The following is a description of a gene set: Mouse Gene Set: REACTOME_IMMUNE_SYSTEM Immune System species: Mus musculus, and this is the list of marker genes: Anxa2, N4bp1, Rap1b, Mgam, Atp6v0a2, Calm2, Try5, Arih2, Il22ra1, Nckap1l, Asb17, Stim1, Dync1li2, Defa36, Kif1a (NCBI Gene Id 403189), Acp3, Tap1, Rab6a, Kif28, Uba6, Ftl2-ps, Znrf2, Ctsl, Cd93, Hexb, Tax1bp1, Ckap4, Tnfrsf8, Tifa, Mapt, Abl1, Capza2 (NCBI Gene Id 76913), Cd80, Arsb, Il10ra, Ltn1, Acaa1b, Il6ra, Nectin2, Dnajc3, Igf2r, Atp8a1, Prkacb, Dnase1l1 (deoxyribonuclease 1-like 1), Stk10, Rap1gap2, Trac, Psmd2, Btbd1, Raet1e, Grb10, Nkiras1, Atp6v1g1, Bcap31, Mme, Plcg2, Il33, Tnfrsf13b, Ighv8-8, Frk (fyn-related kinase), Ptafr, Map3k3, Trat1, Atp6v0e2, Fbxw11, Smarca4, Dctn3, Hectd1, Lyn, Klhl42, Ighv3-8, Ctf1, Sarm1, Psmd14, Ifna2, Vcam1, Gyg1, Rnf138, Pnp2, Syngr1, Ighv13-2, Tubb1, Socs3, Stxbp2 (NCBI Gene Id 97457), Hk3, Cd59b, Cd22, Pdia3, Dsp, Dus2, Eif4a3, Cd46, Icos, Pirb, Siglec1, Cd53, Cd274, Gpr84, Pdzd11, Psma5, Kif26a, Anpep, Fbxo32, Cul1, Psmc5 (NCBI Gene Id 19184), Vat1, Ube2f, Ifnab (NCBI Gene Id 15974), Psme1, Ube2k, Ppp2r5c, Mospd2, Prcp, Slc2a3, Ifna7, Ubr2, Lrr1, Socs2, Ypel5, Psma2, Apaf1, Galns, Bcl10, Siglech, Uba7, Retn (NCBI Gene Id 65097), Socs5, Ube2g1, Il13, B4galt1, Prss1l, Dynlt1a, Bcl2l1, Shc1, Igkv17-121, Fbxo11, Treml2, Ikbke, Prss3, Mapk11, Brwd1, Dync1h1, Cd300lg, H2-M1, Hbb-bt, Map3k8, Defb1, Pstpip1, Ube2l6, Lamp2, Defa39, Tnfsf8, Nos2, Cr2, Psg29, Wasf3, Cd27, Fgg, Lrrc41, Ncf4, Dpp7, Fbxo30, Atad3a, Atp6v1c1, Ms4a2, Ighg3, Cyfip2, Tab1, Art1, Rac2, Irak2, Ifi44, Irak4, Ear14, Txlna, Abca13, Atp6v0e, Fancf, Slc11a1, Tmbim1, Actb, Tnfsf12, Rnf34, Il22ra2, Ppp2r5e, Tnf, Klc2, Ube2v2, H2-M9, Tnfsf13, Ptk2b, Pafah1b2, Ube2j2, Il5ra, Hsp90ab1, Prr5, Cd28, Ifna15, Cul2, Lcp2, Faap24, Ccr6, Sphk1, Kif18a, Hbb-bs, Pigr, Nhlrc3, Txndc5, Tubb4a, Psmb3, Col1a2, Eda, Vrk3, Dsg1a, Xrcc6, Mrc2, Eif4g1, H2-Q4, Igkv8-21 (immunoglobulin kappa variable 8-21), Pdpk1, Bst2, Ube2e2, Cbll1, Ptpn6, Cpn2 (NCBI Gene Id 71756), Sec24a, Stat6, Idh1, Lamp1, Pld3, Capzb, Neu1, Rnf114, Il18 (interleukin 18), Nfkb1, Tnfsf4, Psmd6, Cfb (NCBI Gene Id 14962), Eif4g2, Klhl5, Zap70, Cd96 (CD96 antigen), Becn1, Ear2, Klhl3, Fancl, Fbxo17, Bst1, Sqstm1, Trip12, Hmgb1, Dhx36, Rnf220, Il27ra, Defa38, Ighv12-3, Cd79a, Adar, Wipf1, Ighe, Klrd1, Fos, Sec24c, Fpr2, Psmb6, Ap1m1, Lonrf1, Vav2, Eif4g3, Mlst8, Impdh1, Skp1, Tuba8 (tubulin, alpha 8), Kir3dl1, Irak1, Dnm2, D1Pas1, Trem2, Il5, Psmb7, Pias1, Mavs (NCBI Gene Id 228607), BC051665, Ighv5-12, Tab3, Fpr1 (NCBI Gene Id 14293), Ifitm1, Ighv8-6, Ifit1bl2, Cap1, Inpp5d, Il6, Reg3g, Siglec15, Cd8b1, Igkv2-137, Alad, Edar, Cntf (ciliary neurotrophic factor), Rnf144b, Ddost, Panx1, Colec11, Nfam1, Ube2d1, Asb5, Tspan14, Kif20b, Tollip (toll interacting protein), Rela, Oasl1, Dync1li1, Ms4a3, Btk, Tnfrsf17, Mapkap1, Kif20a, Fcgr1, Camk2d, Lamtor1, Ptprn2, Tuba4a, Il34, Ddx3x (DEAD box helicase 3, X-linked), Uba1, Psmb8, Cul7, Tbc1d10c, C6, Ighv5-12-4, Pglyrp2, Kif4 (NCBI Gene Id 194650), Tnfrsf4, Ep300, Qpct, Anapc4, H2-T10, Svip, Naprt, Actr2, Ighv5-6, C8b (NCBI Gene Id 73971), Plcg1, Rnf123, Tmem30a, Gaa, Rnf19b, Ube2m, Itk, Rab14, Hecw2, Tnfrsf12a, Rab4b, Mapk10 (mitogen-activated protein kinase 10), Rbbp6, Fabp5, Ube2v1, Slc2a5, Tyrobp (TYRO protein tyrosine kinase binding protein), Dynlt1b, Hras, Rapgef4, Hspa1b, Kif11, Ctsa, Eif2ak2, Fbxl7, Ifitm6, Cd3g, Fyb1, Snap29, Ahsg (NCBI Gene Id 11625), Scamp1, Chrnb4, Pgam1, Stk11ip, Nkiras2, Kif12, Mapk14, Igkv16-104, Gusb (glucuronidase, beta), Pdcd1, Sirpa (signal-regulatory protein alpha), Mefv, Cntfr, H3c7, Prdx6, Ifng, Mapk9, Them4, Fbxw5, Prkce, Psme2b, Arpc3, H3c2, Clec4n, Sptbn2, Il31ra, Il20rb, Pde12, Actg1, B2m, Ighv5-15, Serpinb3a, Madcam1, Nfasc, Crkl, Sos1 (SOS Ras/Rac guanine nucleotide exchange factor 1), Eif4a2, Gan, Pa2g4, Sh3kbp1, Fbxl5, Ctsh, Gsdmd, Pdxk, Gstp1, Dctn6, Ybx1, Trbv15, Tnfsf11, Traip, Atg7, Cd40lg, Hpse, Anapc1, Vav3, Ap1b1, Mapk3, Rnf19a, Kbtbd7, Ctse, Nme2, Arl8a (ADP-ribosylation factor-like 8A), Rnf213, Akt1, Fbxo41, Defa23, H2-Q7, Lta, Prdx4, Atp6v1e1, Atp6v1g3, Capn1, Fkbp1a, Defa25, Ppbp, Ube3b, Serpinb1a, Cbl, C1s2, Tnfrsf1b, Ifnlr1, Herc6, Tnfaip6, Ighv3-5, Csk, Cdc26, Rictor, Cnpy3, Psma3, Ptprj, Ufl1, Socs1 (suppressor of cytokine signaling 1, NCBI Gene Id 12703), Capza3, Kctd6, Rab9b, Pfkl, Crtam, Pkp1, Dtx4, Ube2h, Tubb3, Vamp8, Cd44, Pglyrp3 (peptidoglycan recognition protein 3), Tnfrsf14, Uba52, Alpk1, Anapc7, Arpc4, Fkbp5, Sell, Svs3b, Creg1, Tlr2 (toll-like receptor 2), Siah1a, Masp2, Ctso, Nit2, Syk, Ceacam1, Abce1, Ggh, Defa30, Ighv3-1, Txnip, Xdh, Cdc20, Tlr9, Hspa1a, Smurf2, Ticam2, Calm1, Klhl22, Cand1, Tnfsf15 (NCBI Gene Id 326623), Kpna1, Ifngr2, Cd79b, Ifnl2, Irs2, Serpina1b, Kif27, Serpinb10, H2-Ob, Ube4a, Sdcbp (NCBI Gene Id 53378), Uba5, Klrk1, Commd9, Cd34, Kcnab2, Defb30, Rac1, Cblb, Ctsb, Fcgr3, Ighv8-9, Trim21, Myh9, Tuba1a, Asb4, Il20ra, Wipf3, Kir3dl2, Ptprc, Txk, Arih1, Hspa8, Rbsn, Sh3rf1, Il9, Klc3, Tmem63a, Pnp, Pak3, Anapc10, Nfkbia, Ampd3, Pik3r1, Pkm, Calm4 (NCBI Gene Id 93787), Kif1c, C5ar1, Myd88, Il15ra, Icam1, Ighv8-11, Fbxo4, Apeh, Kifap3, Sec23a, H2-Q10, Fbxw7, Mmp9, Ifitm2, Ticam1, Trappc1, Reg3b, Cat, Abl2, Cct2, Pilra, Cd63, Trem1, Ppp2r1b, Elmo2, Fuca2, Trim37, Ighv5-17, Potefam3d, Cfhr1, Ighv5-9, Cpne1, Defb43, Ppl, Rock1, H3c3, Sting1, Ifna9 (NCBI Gene Id 15972), Il24, Treml4, Sdc1, Camp, Lrrc14, Src, Adam10, Mgrn1, Itpr3, Rap2c (NCBI Gene Id 72065), Igkv11-125, Cyld, Cdc16, F2 (coagulation factor II), Fbxl3, Kcmf1, Dnm1, Folr2, Kif2a, Irf9, Lck, Ear1, Bpi, Il23a, Rnaset2b, Kif3c, Det1, Rap2b, Cda, Spsb4, Cxadr, Tslp, S100a11, Bri3, Copb1, Klhl2, Herc3, Rab3d, Olr1, Atp6v0c, Il4ra, Prss2, Itgax, Prkcd, Dtx3l, Ap2s1, Serping1, Npdc1, Defa35, Padi2, Lta4h, Blmh, Defa27, Card9, Rnase6, Camk2a, Psmd8, Defb25, Peli3, Vapa, Psmb4, Fbxl13, Il12a, Brk1, Apob, Ecsit, Bin2, Psmd12, Bpifb2, Commd3, Rnf115, H3c6, Ctsz, Ctsd, Stub1, Dynll2, Tnfaip3, Igkv1-135, Kras, C3ar1, Defb47, Ube2o, Fbxo10, Icam4, Tap2, C1qc, Traf6, Slpi, Kpnb1, Racgap1, Fyn, Faf2, Chga, Tlr4, Psmc3, Atp6v0d2, Rnf25, Qsox1, Relb, Kif19a, Atox1, Il2, Hace1, Rasgrp3, Plekho2, Nod2, Kctd7, H2-M5, Casp8, Rasgrp1, Hgsnat, Edaradd, Tnfrsf9, Mapk1, Fbxl21, C9, Klhl25, Cd4, Rps6ka3, Mx2, Cyfip1, Grap2, Plaur, Pik3ca, Cxcr1, Ppp3ca, Pgm1, Tomm70a, Itch, Ighv7-3, Cep290, Ano6, Pira2, Fbxw4, Il20, Aamp, C1qa, Igkv18-36, Dctn4, Klhl11, Psap, Ubc, Usp18, Cdk1, Ighv7-4, Ighv8-12, Csf1r, Thop1, Tlr8, Kif16b, Cd300c2, Cd101, Hectd3, Atp6v0d1, Vcp, Rnf41 (ring finger protein 41), Atp8b4, Defa24, Il12b, Ltb, Trim25, Serpinb3b, Map2k4, Atp6v1h, Sh2b1 (NCBI Gene Id 77601), Nlrx1, Cdk13, Kbtbd13 (NCBI Gene Id 74492), Fancc, Huwe1, Gzmm, Erap1, Ifi204, Clu, Defa40, Ctss, Il13ra1, Il16, Cnn2, Cd36, H2-T23, Mapkapk3, Anapc5, Fanca, Pik3cd, Prl, Clec4g, Spsb2, Nedd4, H2-M10.6, H3c14, Herc2, Il13ra2 (interleukin 13 receptor, alpha 2), Traf2, Npm1, Ripk1, Psmb5, Hvcn1, Klhl9, Psmc2, Itln1, Pecam1, Rap1a, Kif3a, Canx, Igkv1-99, Spsb1, Cd74, Cdkn1b, Pik3cb, Trim11, Tlr1, Sftpd, Aga, Siglecf, Defa37, Pgm2, Snap25, Pdcd1lg2, Dzip3, Gdi2, Ppp2r1a, Defa3 (NCBI Gene Id 13237), Inppl1, Fbxo22, Itga4, Pianp, Plpp5, Rnf4, Siglecg, Il2rg, Hebp2, 1600012H06Rik, Ifna12 (interferon alpha 12), Peli1 (pellino 1), Fadd, Tarbp2, Wasf2, Cdc27, Psen1 (presenilin 1), Iqgap1, Kif23, Igkv1-88, Pik3r5, Ppia, Hsp90aa1, Psg22, Col1a1, Itgav, Irf3, Ube2l3, Csf1 (NCBI Gene Id 97111), Trpm2, Wwp1, Calr (NCBI Gene Id 12317), Tlr6, Clec4e, Rigi, Dnm3, Mapk7, Mre11a, Yes1, Trbv16, Siglece, Atp11b, Sorbs2, Fbxo9, Ttr, Sec13, Try10 (NCBI Gene Id 436522), Ifnl3, Trim36, Mex3c, Ighv5-9-1, Asb18, Fbxl15, Eef2, Psma7, Ppp2cb, Klhl21, Xiap, Nck1, Akt3, Ly86, Ap1s1 (adaptor protein complex AP-1, sigma 1), Asb9, Kif22, Ppm1b, Il7, Ubox5, Stom, Gh, Ube2w, Il1f10, Atp11a, Fbxw9, 2310033P09Rik, Atf2, Tapbp, Hspa5, Fcer1g, Impdh2, Defb14, Ighv7-2, Faap100, Kif26b, Asb7, Ghdc, Cd47, Cd81, Elane, Glipr1, Anapc2, Krt1, Tnfsf18, Igkv1-110, Tank, Ube2e1, Btnl2, Defa28, Jaml, Orm2, Eif4e3, Ist1, Rhoa, Col17a1, Fbxo21, Degs1, Tuba3a, Fuca1, Dnajc5, H2-DMb1 (histocompatibility 2, class II, locus Mb1, NCBI Gene Id 14999), Jup, Kifc5b, Slco4c1, Chi3l1, Il12rb2, H3c13, Tlr7, Il2ra, Btn2a2, Cotl1, AY761185, Tyk2, Dusp7, Asb8, Camk2g, Hectd2, Surf4, Ube3a (ubiquitin protein ligase E3A), Kif18b (kinesin family member 18B), P2rx7, Defa41, Nlrp4c, Birc3, S100a1, Tubb2b, Defb4, Mapk12, Dctn2, Grn, S100a9, Itpr1, Btn1a1, Il1r1, Magt1, Casp4, Cant1, Cd300a, Fbxl4, Ebi3, Cenpe, Hck, Lcn2, Myo10, Nfkbib, Ear10, Ghr, Hc, Orm3, Atp6v1b1, Ormdl3, Cd3e, Epx, Clec5a, Gpi1, Ube2b, Il18bp, Raf1, Ctnnb1, Pag1, Lat2, Dynlt1f, Ltbr, Il36b, Eef1a1, Fbxl14, Arel1, Ilf3, Itgam, Ube3c, Ifngr1, Bpifb6, Ppp2r5b, Rbx1, Ighv6-6, Mapk8, Clcf1, Igkv2-112, Rab5c, Limk1 (NCBI Gene Id 547389), Il23r, Sugt1, Ifi205, Grb2, Cd247, Mapkapk2, Psmd11, Rnase2a, Fbxo15, Arpc2, Fzr1, Leap2, Sla2, Elob, Mvp, Herc1, Dusp4, Psma4, Fbxl12, Manba, Rel, Il6st, Cracr2a, Ube2q2, Trim39, Blnk, Nckipsd, H3c15, H2-Q2, Trim41, Igkv1-133, Trim50, Lgmn, Hp, Stat3, Nlrc5, Il21r, Nbeal2, Il36a, Znrf1, Faap20, Fgl2, Fbxo2, S100a8, Il21, Ighv5-4, Il1rap, Il22, Icosl, Trav19, Npepps, Stat2, Ubac1, C8g, Prss3l, Defa22, Bpifa1, Nf2, Arhgap9, Ighg1, Chit1, Enpp4, Cd180, Defb42, Psma1, Kifc1, Treml1, Igkv1-132, Nos1, Ifna13, Actr10, Rlim, Il1r2, Ctla4, Pglyrp4, Optn, Serpinb3c, Ighv16-1 (NCBI Gene Id 629812), Klhl13, C1ra, Rab7, Tubb5, Il1rapl1, Ighv3-4, Lifr, Tbk1, Cab39, Fbxo31, Plau, Kif21a, Sumo1, Abi2, Pja1, Ywhaz, Asb10, Asb13, Ifna5, H2-M11, Ighd, Nlrp3, Eppin, Rnf130, Gca, Jak2, Jun, Casp2, Fbxo44, Traf3, Vamp3, Creb1, Vtn, Mif, Pvr, Cd8a, Gm2a, Mcemp1, Defa42, Slamf6, Dgat1, Defa17, Vhl, Iglc2 (NCBI Gene Id 16138), Klc4, Klhl41, Hrnr, Mmp25, Itpr2, Cul3, Prkn, Pik3r3, H2-Oa, Flg2, Fbxw10, Mapk13, Ifnar1, Myo1c, Fancb, Ndufc2, Ap1m2, Aprt, Fcer1a, Dync1i2, Stat5b, Kif5a, Kif9, Sec24b, Fbxw17, Lat, Tnfsf9, Dcaf1, Actr1b, Trav16, Mgst1, Unc93b1, Mtor, Rps6ka1, Irf5, Man2b1, Il19, Il15, Rnf126, Map3k7, Rhog, Anapc13, H2-T22, Arpc1b, Clec4d, Sec31a, Timp2, Lpcat1, Pik3c3, C5ar2, Psmd3, Kif1b, Igkv15-103, Ncf2 (NCBI Gene Id 17970), Flnb, Ap1g1, Cpn1, Ap2m1, Ctsk, Actr3 (NCBI Gene Id 74117), Defa5, Tmem179b, Myo5a, H3c8, Aldoc, Dapp1, Arpc1a, Igkv1-35, Pak1, Tuba1c, Ube2n, Il11ra1, Ube2q1, Myo9b, Ube2c (NCBI Gene Id 68612), Mkrn1, H2-M10.4, Nos3, Nfatc1 (nuclear factor of activated T cells, cytoplasmic, calcineurin dependent 1), Csf2rb, Igkv2-109, H3c1, Map2k6, Ctsg, Ptprz1, Arsa, Tmc6, Fga, Atp6v1c2, Ube2r2, Pglyrp1, Bpifa2, Slc27a2, Il10, Gsn, Bpifb1, Hsp90b1, Ctsc (cathepsin C), Rnf217, Cenpx, Adrm1, Itgb2, Rab31, Tnfsf14, Srp14, Ptpn22, Ptges2, Slc44a2, H2-Aa, Cd160, Ighv3-6, Ripk3, Rab10, Rhof, Dhx9, Sar1b, Prkcq, Defa21, Ikbkg, Gns, Rasgrp2 (NCBI Gene Id 386467), Ptpn11, Fcgr2b, Stat5a, Cfd, P4hb, Il36rn (interleukin 36 receptor antagonist), Irak3 (NCBI Gene Id 73914), Prlr, Ager, Stx1a, Reg3a, Cd55, Vamp2, Rnaset2a, Nfkb2, Crispld2, Calm3, Baiap2, Cd14, Ppp2ca, Ap2a1, Ly96, Actr1a, Tubb2a (tubulin, beta 2A class IIA), Igkv1-122, Trp53, Tnfrsf18, Ube2z, Arpc5, Usp14, Defa31, Ifna11, Frmpd3, Traf7 (NCBI Gene Id 224619), Asb6, Asb16, Acly, Crk, Csf2 (NCBI Gene Id 12981), Lif (leukemia inhibitory factor), Ifna4, Arg1, Ighv5-2, Stx4a, Ptpn4, Ikbkb, Ube3d, Armc8, Lrrc7, Cd200, Ddx41, Eif4e, Prtn3, Klc1, Ifitm3, Asb12, H2-Eb1, H2-M3, Kif5b, Kif15, Psmc1, Osm, Tirap, Klhl20, Ptk2, Cfp, Ppp3cb, Atp6v0a4, H3c11, Atp6v1g2, Herc4, Masp1, Hspa1l, Stx3, Cd200r2, Kbtbd8, Eea1, Cxcr2, Cd70, H2-M10.2, Lamtor3, Cd3d, Klrc3, Wsb1, Rab18, Prg3, Tuba1b, Kif2b, Nfatc3, Pld4, Cfi, Ptpn1, Fgr, H2-Q6, Tarm1, Gsdme, Fbxw2, Cdc23, Ncf1, Dnajc13 (DnaJ heat shock protein family (Hsp40) member C13), Lpo, Defa29, Pik3cg, Ifnb1, Lmo7, Ubr1, Kif2c, Psmb1 (proteasome (prosome, macropain) subunit, beta type 1), Prkg1, Rab5b, Fbxo40, Tuba3b, H2-K1, Fbxl16, Serpinb12, Kif3b, C2, App, Irf7, Dctn1, Defb18, Serpina3f, Mndal, Klrc2, Tcirg1, Eif4a1, Sh2b3, Defa26, Atp6v1f, Map3k14, Mbl2 (NCBI Gene Id 17195), Rnase2b, Trim69, Fbxl8, Casp3, Uba52rt, Psme2, Aldoa, Cd33, Nod1, Ear6, Flt3l, Pygb (brain glycogen phosphorylase), Cmtm6, Ppp3r1, Mylip, Atp7a, Mmp8 (matrix metallopeptidase 8), Erp44, H2-DMb2, Tnfrsf11b, Gmfg, Sec24d (NCBI Gene Id 69608), Mlec (NCBI Gene Id 76765), Lamtor2, Peli2, Ap1s2, Psmb10, Vav1, Defa34, Ighv6-5, Cystm1, Cyb5r3, Atp6v1b2, Nlrp1a, Psmd1, Oscar, Tnfrsf13c, Iqgap2, Cd1d1, Cdc42 (NCBI Gene Id 12540), Pik3r6 (NCBI Gene Id 432574), C7, Psmc4, Tab2, Csf3, Itgb7, Defb19, H2-DMa, Defa32, Fance, Defa43, Cd177, Stbd1, Lrsam1, Cltc, Rps27a, Il9r, Clec12a, Adam8 (NCBI Gene Id 11501), Snca, Cpne3, Psma6, Il31, Ighv3-3, Psmd13, Ptx3, Trim32, Dock2, Fbxw8, Kifc2, Fbxl19, H2-Eb2, Mpo, Dynlt1c, Plpp4, Cyba, Card11, Csf2rb2, Foxo3 (forkhead box O3), Skp2, Rbck1, Fancm (NCBI Gene Id 52599), Fth1, Rab27a, Itgal, H2-M10.3, Prg2, Rnf7, H3c10, Adgrg3, Map2k7, Socs6, Cd68, Rab44, Prss1, Siah2, Agpat2, Pin1, Ncstn, Rps6ka5, Ltf, Hspa2, Il18rap, Btbd6, Igkv1-131, Atf1, Ifi44l, Fcna, Ighg2c, Try4, Defa2, Il10rb, Pgrmc1, Ighv5-16, Dera, Rap1gap, Psmd7, Unc13d, Fbxl18, Rnf182, Sec22b, Fbxo6 (F-box protein 6), Rnasel, Trim71, Rilp, Lnx1, Il1b, Cfh, Ptprb, Dok3, Vnn1, Pira13, Myh2, Il36g, Snap23 (synaptosomal-associated protein 23), Ceacam2, Pja2, Osmr, Bcl2, Reg3d, H3c4, Rps6ka2, Aoc1, Csnk2b, Cd300e, Kif13b, Defb36, Anapc11 (anaphase promoting complex subunit 11), Pycard, Ap2b1, Camk2b, Il7r, H2-M2 (histocompatibility 2, M region locus 2), Cxcl1, Defb28, Cpb2, Cd19, C1qb, Ubr4, Slamf7, Plac8, Mib2, Sos2 (SOS Ras/Rho guanine nucleotide exchange factor 2), Birc2, Arf1, Trim9, Nckap1, Asb11, Cenps, Aim2, Elmo1, Gla, Txn1, Golga7, Npc2, Fancg, Rnf6, Rab37 (RAB37, member RAS oncogene family), Atp6v1d, Vcl, Dctn5, Orm1, Pdap1, Ighv8-2, Il27, Dynll1, Fcgr4, Serpinb3d, Pik3r4, Il1rl2, Ccnf, Psmc6, Vps35l, Dync1i1, Adgre5, Pla2g2a, Pla2g6, Prkcb, Rab24, Lair1, Atp6v0a1, Aldh3b1, Tnfrsf11a, Gstp2, Lilra6, Ripk2, Pira12, Pik3ap1, Prkra, Ifna16, Iglc1, Glb1, Dsn1, Col2a1, Olfm4, Defa20, Clta, Ifna6, Cpped1, Pten, S100b, Ube2g2, Tnip2 (NCBI Gene Id 69105), Casp9, Ube2a, Atp6ap2, Ighv6-3, Tasl, Cd40, Ilf2, Ighv8-4, Cd86 (CD86 antigen), Uba3, H2-M10.5, Col3a1, Bpifb4, Sh3gl2, Ppp2r5a, Ubb, Eda2r, Ube2s, Il3, Ifnar2, Asb14, Il1rn, Il11, Osbpl1a, Igkv20-101-2, H2-Q1, Lag3, Pld2, Fbxo7, Arhgap45, Ube2d3, Pik3r2, Ywhab, Atp6v1a, Asah1, Lyz2, P2rx1, Kif6, Dock1, Ap2a2, Tubb4b, Ostf1, Sipa1, C4b, Rapgef3, Tom1, Fbxl20, Alox5, Xrcc5, Ap1s3, Slc15a4, Atp6v0b, Ube2j1, Il12rb1, Psg18, Serpinb6a, Gm5150, Lilra5, Sla, Unkl, Smurf1, Nedd4l, Ube2e3, Tnfsf13b, A1bg, Rnf111, Hcst, Ifna14, Cybb, Fbxo27, Isg15, Ppp2r5d, Il4, H2-Ab1, Sptan1, Wasf1, H2-M10.1, Casp1, Akt2, Eif4e2, Fcnb, Cst3, Btnl9, Ctsf, Crlf1, Igkv1-117, Cd300lb, Fgb, Tubb6, Ighv8-5, Psmb2, Pak2 (p21 (RAC1) activated kinase 2), Il1rl1, Colec10, Kif21b, Ighv8-13, Defb48, Prkaca, Ifi211 (NCBI Gene Id 381308), Potefam3c, Icam2, Keap1, Serpina1c, C3, Tubal3, Il1a, Rab3a, Ifna1, Ighv6-7, Cd300c, Pygl, Il2rb, Asb1, Icam5, Crp, Rchy1, Nfatc2, Cstb, Tnfrsf1a, Agl, Trib3, Cd207, Cd209a, Tnfrsf25, Ifi30, Ifitm7, Chuk, Cfhr4, Mrc1, Rapgef1, Lnpep, Diaph1, Trim56, Glmn, Defb21, Ptpn2, C8a, Lbp, Trpc1, Dusp6, H2-Ea, Malt1, Il18r1, Cct8, Svs3a (seminal vesicle secretory protein 3A), Ighv6-4, Hmox2, Cdc34, Dusp3, Klrc1, Map2k3, Tpp2 (tripeptidyl peptidase II), Dsc1, Igll1, Abi1, Rnf14, Sftpa1, Itgb1, Cd226, Eloc, Atp6v1e2, Ube2d2a